Given this list of marker genes MCM4, MCM5, MCM2, POLD3, MCM3, MCM6, PIF1, MCM7, here is a description of the gene set: Human Gene Set: KEGG_MEDICUS_REFERENCE_BREAK_INDUCED_REPLICATION Break induced replication. Pathway ID: N01450. Pathway type: Reference. Pathway class: nt06506 Double-strand break repair. Pathway Definition from KEGG: POLD3 == PIF1,MCM species: Homo sapiens